The following is a description of a gene set: species: Homo sapiens Human Gene Set: MIR4524B_3P from publication Chen Y, Wang X (PMID 31504780) Genes predicted to be targets of miRBase v22 microRNA hsa-miR-4524b-3p in miRDB v6.0 with MirTarget v4 prediction scores > 80 (high confidence targets)., and this is the list of marker genes: SPTY2D1, NSL1, RAB6B, ABCG2, NCOR2, PTPRB, IBA57 (iron-sulfur cluster assembly factor IBA57), FARP1, DPP3, MEF2A, ZC3H18, SH3RF1, LSM11, CNTNAP5, MECP2, PRRG3, ZNRF3, CTSK, PDE11A, GNAL, ERP27, MYF6, IGF2BP3, RTN4, MMS22L, ZC3HAV1L, YWHAB, MARCHF9, UBN2, FIGN, COPRS, FOXRED2, PIP5K1A, SHISA9, FAM110B, ADCY2, TMEM242, RGS8, ACSL5, SLITRK4, SERPINE2, HYCC2 (NCBI Gene Id 285172), SF3B3, AMPD3 (NCBI Gene Id 272), ZNF80, PROX2, DENND1B, CHSY1, ADCY6, PLEKHF2, GPR139, TP53AIP1, CAMSAP1, LPAR3, RAB10 (NCBI Gene Id 51140), ARHGAP12, FIGNL2, KHDRBS2, KAT6A, FLOT2, MRFAP1, TOX, GASK1B, IDH3A, ATXN7L3, HS3ST5, COLQ, REPS1, SERPINI2, CCDC6, ATP5F1E (NCBI Gene Id 514), HMG20A (high mobility group 20A)